Given this list of marker genes ARHGAP42, SEL1L, PTGS1, PPM1E, VCF1, MCCC2, OSBPL8, ZBTB20, PTP4A2, MRPS7, DNAJC18, MED13, NEGR1, GRAMD1C, ARID1A, MAMDC2, RAB28 (NCBI Gene Id 9364), GPT2, BMAL2 (basic helix-loop-helix ARNT like 2), SMCO4 (NCBI Gene Id 56935), PLCXD3, EIF3A (NCBI Gene Id 8661), KPNA1, SMIM10L1, SCML2, KMT2C, APH1B, ATAD1, CPED1, TM9SF3, CLTA, ASZ1, ABI1, ATXN7L1, NCBP2, USP46, AEBP2, ZMYM6, XPNPEP1, AUNIP, TAOK3 (TAO kinase 3), SLC1A2 (NCBI Gene Id 6506), TMCC3, CNKSR2, OSCP1, TCF7L2, PCMTD1, KIF5B, DNAJC21, RIMKLB, CCN1, DENND1B, MECOM, FGFR2, FBXW11, DUSP16, YWHAG, MAPRE1, ONECUT2, MATR3, DDX3Y, XRCC5, ATRX, THNSL1, WDSUB1, GUCY1A2, WBP11, PURA, MAP9, TBCA, TAF5L, ARHGAP5, ANKRD44, ZNF827, NKAIN2, LACC1, CEP350, SLC30A8, SPTSSB, RYK, TUSC3, CEP135, EIF1AX, CALCR, TRA2A, G3BP2, SNTG1, E2F5, CYP19A1, NAV3, ELMOD2, PPP4R3B, KLF12, IKZF2, CCSER1, ILF3, MAP1B, RO60, RAP2C, ZNF280D, ARIH1, TNRC6B, STK17A, FAM217A, TIPARP, TRPC6, METTL4, ARPC5, MYH10, HMCN1, PPM1B, CDC42BPA, ZHX1, FAM135A, ZNF275, GRM5, PTPRG, ZNRF1, DTNA, DNAAF9, HECW2, UNC5D (unc-5 netrin receptor D), TASP1, UFM1, ANKRD42, CD3G, ARID1B, TTC39C, RNF152, TBC1D9, UPF3A, PTGER2, SEMA3C, AGPAT5, NR2F2, NECAB1, EXOC5, ZNF804A, ZDHHC17, MTCL1, TRIM23, F2R, ASB15 (NCBI Gene Id 142685), MEX3B, IGSF22, GNA13, POU2F1, TUT7, SP4, ZNF37A, TSC1, DDX3X, CHIC1, RER1, THRB, CDH20, DKC1, PEAR1, CKS2, SKIDA1, MOB1B, PCDH19, RIMKLA, NETO1, COL7A1, SNX30, GORAB (golgin, RAB6 interacting), RPL7L1, XBP1, ACO1, TMEM170B, ARL5B, EBPL, SMURF1, TMEM26, PLXNA4, ITGB1BP1, MBNL3, RNPC3, CFAP184, BOD1L1, MED27, NPM1, VSNL1, SCN3B, UBQLN2, E2F6, EIF4E, SPTBN1, GUF1, ROR1, ZIC3, SOWAHB, CTXN2, SMARCC1, CSDE1, ZNF544, ANXA4, NR3C1, ADCY6, PRXL2C, MED12L, ODAD2, POLR2M, KRT85, OTULINL, FAM20C, CYSTM1, MTMR3, CPOX, ASPH, DR1, LINC02694, KCNAB1, CMPK1, here is a description of the gene set: from publication Chen Y, Wang X (PMID 31504780) studied in species Homo sapiens Genes predicted to be targets of miRBase v22 microRNA hsa-miR-181b-2-3p, hsa-miR-181b-3p in miRDB v6.0 with MirTarget v4 prediction scores > 80 (high confidence targets). Human Gene Set: MIR181B_2_3P_MIR181B_3P